Given this list of marker genes DLGAP4, CAP1, AMOT, CHMP2B, PFN2, MRTFB, SARM1, CTTNBP2, ABL1, PDXP, WASF1, CAMKV, STAU1, CLN3, KIF5B, DLGAP3, DIXDC1, PRMT8, WASF3, DRD1, EPHA4, REST, FILIP1, CTTN, CFL1, ITSN1, STRN4, CYFIP1, RHOA, ITPKA, AGAP1, PFN1, RHOB, ARHGAP44, BAIAP2, ABI3, SPTB, PGRMC1, CTNNA2, EGLN1, RAP1B, ZDHHC17, here is a description of the gene set: species: Homo sapiens Human Gene Set: GOBP_MODIFICATION_OF_SYNAPTIC_STRUCTURE Any process that modifies the structure/morphology of a synapse.